Given this list of marker genes Nup93, Mtor, Sec13, Hspa12a, Nup214, Rpa1, Camk2g, Hspa12b, Nup50, Nup58, St13 (NCBI Gene Id 70356), Nup88, Nup188, Nup155, Hspa14, Bag1, Rpa3 (replication protein A3), Rpa2, Nup37, Ywhae, Bag4, Cryab, Sirt1, Pom121, Hspa1a, Nup98, Camk2d (calcium/calmodulin-dependent protein kinase II, delta), Hspb8, Hspa4l, Hsp90ab1, Nup153, Ndc1, Hspa1l, Hspa1b (NCBI Gene Id 15511), Nup107, Nup160, Bag5, Dnajb6, Hikeshi, Hsf1, Mapkapk2 (MAP kinase-activated protein kinase 2), Hspa2 (heat shock protein 2), Hsp90aa1, Hsph1, Nup205, Camk2b, Mlst8, Hspa8, Rptor, Ranbp2, Nup133, Ptges3, Bag2 (NCBI Gene Id 74827), Nup35, Nup42, Mapk1, Seh1l, Nup85, Hspa13, Nup54, Bag3, Akt1s1, Camk2a, Fkbp4, Nup43, Vcp, Tpr, Gsk3b, Hdac6, Ep300, Nup62, Rae1, Hspa9, Mapk3 (mitogen-activated protein kinase 3), Hsbp1, Eef1a1, Aaas, Hspa4, Dnajb1, Nup210, Dnajc2, Hspa5, Rps19bp1, here is a description of the gene set: Cellular response to heat stress studied in species Mus musculus Mouse Gene Set: REACTOME_CELLULAR_RESPONSE_TO_HEAT_STRESS